Given this list of marker genes Ptafr, Gpr171, Gpr87, P2ry13, P2ry4, P2ry2, P2ry1, P2ry12, P2ry6, Gpr34, P2ry14, here is a description of the gene set: studied in species Mus musculus Combining with a purine nucleotide and transmitting the signal across the membrane by activating an associated G-protein; promotes the exchange of GDP for GTP on the alpha subunit of a heterotrimeric G-protein complex. Mouse Gene Set: GOMF_G_PROTEIN_COUPLED_PURINERGIC_NUCLEOTIDE_RECEPTOR_ACTIVITY